The following is a description of a gene set: Genes predicted to be targets of miRBase v22 microRNA hsa-miR-6508-5p in miRDB v6.0 with MirTarget v4 prediction scores > 80 (high confidence targets). species: Homo sapiens from publication Chen Y, Wang X (PMID 31504780) Human Gene Set: MIR6508_5P, and this is the list of marker genes: FOXI1, CHERP, KCNH8 (potassium voltage-gated channel subfamily H member 8), CYFIP2, RYK, PEX11B, LRRC59, PCGF3, YPEL5, NCOA2 (NCBI Gene Id 10499), TAF7, NHLRC2, ADIPOR1, XKR7, C1orf185, MEMO1, USP39, BOLA2-SMG1P6, PLPPR1, WDR33, ATP11A, BRWD3, TXLNB, TFRC, TRIM9, KDELR1, NRARP, EIF2AK3 (NCBI Gene Id 9451), XRN1, SLC26A2, RAB10, CNTN1 (NCBI Gene Id 1272), PTPN21, SLC12A2, KMT2A, RNF11, GDI2, HOXA1, RAB1A, CFAP300, ASB11, PDK3, PEX11A (peroxisomal biogenesis factor 11 alpha), ZNF793, LAMC1, HNMT, SIX5, PIP4P2, CEP97 (centrosomal protein 97), FRMPD4, MMRN1, FRY, TRERF1 (NCBI Gene Id 9565), DLG3, HIF3A, ALG13, ATP6V0D2, PABIR3, DUSP18, FPGT, USP45, ZNF652, CENPK, KHDRBS2, GUCY1A2, GIMAP1, TENM1, PRTG, TMCO1, ARB2A, SNX4, RPS6KA6, UBE2Z, SOCS2, KCNJ14, CATSPERB, PLAC1, NAP1L4, ANO5, PHEX, ZCCHC8, FMN2, MED13L, TXNDC16, BLOC1S6, PARP11, PSIP1, CORO1C, PSMA1, LRBA, ANXA10 (annexin A10), ANKS1B, SERINC5, ZNF850, SEC24D, STRN3, TNFSF18, ACTR3, ZMAT4, ZNF681, SYT9, MAP2K4, RNF182, RNF111, HOMER3, MBNL3, SCN3A, ALPL, RRP15, TMEM127, GPATCH2L, CADM2, CDH26, HSPA4L, NHERF1, PAX5, CRYM, DEFB118, CREBRF, SEPTIN2, PRICKLE2, BCL11A, KLHL20, CTDSPL (NCBI Gene Id 10217), PLEKHH3, CAP1, RCAN1, SPATA6, ZNF80, FAM76B, PRKAB1, NPFFR2, MUC15, SAMTOR, USF3, CA2, KRT34, CDK6, OTUD1, SLC10A4, ATXN7, LARP7, GMNC, NXF1, NFIB, PRKCG, RBM41, SPG21, VSTM2A, CUL3 (cullin 3), ACER3, GTPBP4, RND3, LRCH2, GOLIM4, ALG14, PEDS1-UBE2V1, PRDX6 (NCBI Gene Id 9588), TTLL7, NETO2, GABRP, PDCD6, MRPS35, AMDHD1, GPD1L, ATRN, LMNTD1, SHFL, MINDY2, HEMK1, B3GLCT, KPNA1, RHOBTB3, MGARP, NMT2 (N-myristoyltransferase 2), NECAB2, DLG5, CAB39, DHX29, FAM118B, NCKAP5, SDC4, SYNPR, ZNF460, ICMT, ARID2, USP49, FGF14, HIVEP2, TTPAL, KCTD5, TSPAN12, LGI2, PTAR1, CABLES1, GALNT2, TNPO1, LIN7A, CHURC1, CALD1, SEMA3C, PPP6R3, CELF1, FRS2, BCL7B, FNDC3A, IKZF2, RHOA, AMD1, FICD, RORA, KLF10, PPARGC1A, TERB2, ASTN2, COL19A1, RAP2C, ONECUT2, GPATCH2, LIN28B, PTPRN (NCBI Gene Id 5798), ANKRD34C, XPR1, TP53INP2, GIMAP4, CYTIP, PPP4R1, PAG1, LGR4, TEAD1, ZNF552, IFT57, IPO8, KLHL7, BMPER, CA10, CIAO2A, NANOS1, ZCCHC2, PAK4, RNF24, CYFIP1, SPMIP4, RNF14, TRPS1, APC, BPNT2 (3'(2'), 5'-bisphosphate nucleotidase 2), FLT1, SRCIN1, GAS7, HEXIM1, ANKRD44, RIMBP2, SBSPON, ZNF772 (NCBI Gene Id 400720), SENP6, ARHGAP42, CELF3, DNAJC27, ABRAXAS2, CASP8, HSPA9, TANC2, CCNG1, GPN1, PABPC1L2A, KDSR, LRP8, ZEB1, RBAK, OSBPL8, C1QBP, SERPINB5, MITF, SREK1 (NCBI Gene Id 57833), TMEM38B, LPP, CHGA, MTRF1L, ABHD5, TMEM168, MAP7, THSD7A, NMNAT1, MAML3, MYH10, OCRL, MRAS, TRIM47, BVES, VWC2, NID2, NSG2, SSPN, MARF1, CHIC1, SLC2A13, CCSER2, TCAIM, FOXL2, SREK1IP1, CYRIA, SKIL, NALF1, HEATR6, CDH6, BCL2L1, LHCGR, CBLB, ARSJ, WDR76, PRKAR1A, TGS1, UBE2V1, OOSP2, ANKRD42, MIB1, MTMR2, EIF4E, GCM1, TEF, RSPO2, JPH4, HMGN3, MAP10, FUT1, INTS14, TCF12, SCAMP1, GRAMD2A, AHR, DUSP16, AUTS2, TBC1D2B (NCBI Gene Id 91449), THSD7B, SH3BGRL2, STK32C, LCORL, NUCKS1, KCND2, ZNF131, SGMS1, MED26, TBL1X, SH3BP5, KIAA1958